Given this list of marker genes ECE1, EDNRA, ISL1, SIX1, EYA1, FOXI3, NKX2-6, HOXA2, FOLR1, EDN1, TGFBR1, TBX2, BMPR1A, FGF8, BMP5, BMPR2, TGFB2, RIPPLY3, GATA3, ACVR1, HES1, NOG (noggin), NKX3-1, SIX4, TBX1, BMP4, BMP7, PLXNA2, PTCH1, MEGF8, ADGRF5, NKX2-5, here is a description of the gene set: Human Gene Set: GOBP_PHARYNGEAL_SYSTEM_DEVELOPMENT The process whose specific outcome is the progression of the pharyngeal system over time, from its formation to the mature structure. The pharyngeal system is a transient embryonic complex that is specific to vertebrates. It comprises the pharyngeal arches, bulges of tissues of mesoderm and neural crest derivation through which pass nerves and pharyngeal arch arteries. The arches are separated internally by pharyngeal pouches, evaginations of foregut endoderm, and externally by pharyngeal clefts, invaginations of surface ectoderm. The development of the system ends when the structure it contributes to are forming: the thymus, thyroid, parathyroids, maxilla, mandible, aortic arch, cardiac outflow tract, external and middle ear. species: Homo sapiens